Given this list of marker genes RBM8A, PLAA, ZNHIT3 (zinc finger HIT-type containing 3), TGM1, RNF13, here is a description of the gene set: Human Gene Set: HP_EDEMA_OF_THE_DORSUM_OF_FEET Edema of the dorsum of feet An abnormal accumulation of fluid beneath the skin on the back of the feet. studied in species Homo sapiens